Given this list of marker genes Rgma, Adam17, Lrig2, Lrp1, D130043K22Rik, Grn, Apoa4, Nrg1, Dag1, Nrep, Lamb2, Inpp5f, Rtn4rl1, Flna, Jak2, Enpp1, Jun, Ctnna1, Tspo (NCBI Gene Id 12257), Pten, Xylt1, Tnc, Nefh, Dhfr, Bcl2 (B cell leukemia/lymphoma 2), Neo1, Bex1, Cntf, Mapk8ip3, Mmp2, Rtca, Ntrk3, Apod, Igf1r, Ndel1, Stk24 (NCBI Gene Id 69763), Chl1, Rtn4rl2, Nefl (NCBI Gene Id 18039), Mag (NCBI Gene Id 17136), Folr1, Klf4, Rtn4r, Map1b, Ptn, Apoe, Mtr, Apoa1, Braf, Ptprf, Cers2, Map2k1, Fkbp1b, Kremen1, Scarf1, Tnr, Pum2, Ptprs, Map2k2, Gap43, Omg, Epha4, Cspg5, here is a description of the gene set: studied in species Mus musculus The regrowth of axons following their loss or damage. Mouse Gene Set: GOBP_AXON_REGENERATION